Given this list of marker genes SERPINA5, THBD, PROC, SERPINE2, PF4V1, F13A1, F2, PROCR, FGG, FGB, PROS1, F8, F2R, F5, SERPINC1, PF4, FGA, CD177, F13B, PRTN3, SERPIND1, F10, here is a description of the gene set: studied in species Homo sapiens Common Pathway of Fibrin Clot Formation Human Gene Set: REACTOME_COMMON_PATHWAY_OF_FIBRIN_CLOT_FORMATION